Given this list of marker genes WNT6, GBF1, ACE2, PPIB, ENAM, GGCX (NCBI Gene Id 2677), SRL, MARCOL, MATN3, MEN1, ADAM10, MZB1, IL23A (NCBI Gene Id 51561), FGF23, COL2A1, SERPINA1, SUMF2, CSF1, MYDGF, COL15A1, COL6A1, SUMF1, MIA3, KTN1, MSLN, SELENOM, TXNDC5, COL7A1, DBI, ERO1B, F9, TRDN (triadin), APOA4, VGF, GPC3, CCN1, AHSG, ADAMTS13, CASQ1, FBN1, EVA1A, SERPING1, COL21A1, UGGT2, ADAMTS5, ARSL, COL20A1, SHISA5, LAMB1, DMP1, PENK, AMTN, BCHE, THBS1, TMEM132A, MTTP, TXNDC12, COL4A4, COL23A1, SCG2, SERPINH1, COLGALT1, VTN, PDIA5, COL6A2, P3H2, GPX8, COL14A1, ADAMTS7, ERP29, ANO8, ASPH, RNASET2, COL5A1, SPARCL1, ADAM17, PDGFC, PRKCSH, MFGE8, CYP2W1, CHRDL1, LAMC1, IL6, COL4A1, ADAMTSL4, LRPAP1, COL8A2, WNT7A, IGFBP7, WNT5A, COL4A3, PLOD3, ERLEC1, COL16A1, ERP44, SPP1, ERAP2, IL12B, COL11A1, TOR1B, RDH5, NOTUM, COL13A1, P4HA1, COL5A2, RCN2, TSPAN14, TGOLN2, C4A, ARSH, COL4A6, CTSC, EOGT, PTGS2, CKAP4, MXRA8, CERCAM, H6PD, MEPE, MANF, PROC, WNT5B, MELTF (melanotransferrin), PDIA2, CHGB, TOR4A, ERO1A, SPON1, CRTAP, DNAJB11, ARSK, COL26A1, ADAMTSL1, COL4A2, SELENOF, MGAT4A, DNAJC3, CNPY3, COL8A1, CALU, SLC27A2, COL9A1, AMBN, DAG1, COL9A2, LAMB2, WNT3, CFP, ERP27, CLN6 (NCBI Gene Id 54982), POGLUT2 (NCBI Gene Id 79070), FSTL3, IGFBP5 (NCBI Gene Id 3488), UGGT1, COL27A1, TNC, RCN3, CANX, CST3, FKBP10, SIL1, APOA2, CDH2, EDEM3, SDF2L1, SERPINC1, TF, SDC2, COL4A5, C3, PCSK9 (proprotein convertase subtilisin/kexin type 9), SERPIND1, APP, AMELX, ARSI, HYOU1 (hypoxia up-regulated 1), POGLUT3, COL5A3, P4HA3, ALB, VKORC1, COL24A1, APOB, WNT1, WNT4, IGFBP4, TOR2A, FMO1, INS, CES2, GPX7, BMP4, P4HA2, COL22A1, F2, NUCB1, LIPC, F5, COL25A1, TSPAN15, POGLUT1, HRC (NCBI Gene Id 3270), CTSZ, OS9, GIP, WNT3A, FGG, SPP2, MINPP1, F8, TIMP1, JMJD8, COL6A3, TOR3A, GHRL, IL27 (interleukin 27), CP, TOR1A, TSPAN5, PRSS23, APOL1, PDIA6, MAPK3, PLAUR, COL10A1, FKBP7, EDN1, ARSA, MBTPS1, COL3A1, COL1A1, VWA1, BACE1, COL19A1, APLP2, APOA5, ARSJ, HSPA5, ERAP1, VCPIP1, PDGFA, IGFBP1, P3H1, IGFBP3 (NCBI Gene Id 3486), TSPAN33, WNT7B, SCG3, FKBP14, COLGALT2 (collagen beta(1-O)galactosyltransferase 2), PROZ, ARSB, TXNDC16, LTBP1, GANAB, FGA (NCBI Gene Id 2243), HSP90B1, CALR3, LGALS1, ITIH2, COL9A3, CASQ2, GCG, ESD, STC2, QSOX1, EBI3, VCAN, FLT3, STS, KNG1, CALR, BGLAP (NCBI Gene Id 632), BDNF, SHH, PDGFD, COL28A1, MAPK1, ARSF, CCDC134, SERPINA10, P4HB, FN1, F7 (NCBI Gene Id 14068), F10, AFP, APOA1, APOE, GOLM1, WFS1, TMEM43, B2M, PDIA4, DNAJC10, PNPLA2, GAS6, COL1A2, ARSG, COL11A2, PDIA3, EDEM2, BPIFB2, FUCA2, COL17A1, COL18A1, CLU, CES3, FAM20C, DNAJB9, FOXRED2, RCN1, IL12A, BMP15, PDGFB, ARSD, CD4, CES1, COL12A1, FSTL1, here is a description of the gene set: The volume enclosed by the membranes of the endoplasmic reticulum. studied in species Homo sapiens Human Gene Set: GOCC_ENDOPLASMIC_RETICULUM_LUMEN